The following is a description of a gene set: Genes predicted to be targets of miRBase v22 microRNA hsa-miR-548ag in miRDB v6.0 with MirTarget v4 prediction scores > 80 (high confidence targets). Human Gene Set: MIR548AG from publication Chen Y, Wang X (PMID 31504780) studied in species Homo sapiens, and this is the list of marker genes: CAMSAP2, SPDYE5, RNF38, FIP1L1, COG5, PSME3, LMBR1, RIOX1, TMEM200A, PSMA8, BCAT1, ZNF730, DENND4C, C4orf46, APPBP2, TRIM13, CEP97, PDE6C, DICER1, ZC2HC1C, C21orf91, PURB, PF4, DENND1A, STXBP1, NFYB, PAK2, PSD3, CYP2J2, RWDD4, CRISPLD1, PDLIM5, GDNF, IQCK, LPP, COX5A, POLR3G, SLC15A1, ZNF461, OBSL1, MORC3, CENPK, ITSN1, STAU2, ANKRD13A, ZEB2, LCOR, ZHX2, GNG12, P2RY12, BACH2, SLC25A12 (solute carrier family 25 member 12), KRTAP9-9, MRO, CRNKL1 (NCBI Gene Id 51340), RREB1, ULK2, U2AF1, RORB, DCAKD, UBE2W, SON, GASK1B, PCDH15, TPR, PCMTD1, CDC14A, C1orf115, TOMM5, CD164, TCFL5, HPCAL4, NEK2, MAP7, RGS9BP, SPDYE1, GPM6A, ZNF699, HELQ, PABPC5, INSIG1, SPDYE3, TNKS2, ZNF585B, MFN1, VAPA (VAMP associated protein A), ITPR3, PIK3C2B, RFXAP, HMCN1, ZNF777, SLC17A6, USP42, SP110, ZNF716, TMEM178B, ANKRD17, TMEM229A, BICD2, RBMXL3, PDE7A, DIXDC1, UBE2E3, GUCY1A2, BMP3, STAM, RDX, QKI, B3GNT5, SASS6, ZNF362, EFEMP1, WDR20, PSMD7, PDHA1, PPP3R1, LAMTOR5, ENSG00000275895 (NCBI Gene Id 102724594), KDM2B, TNIK, MPRIP, TRIP11, CDH19, PPP1R9A, FBXL4, TMPRSS11B, EPSTI1, MTUS1, NEMP1, MOB1B, ZNF43 (NCBI Gene Id 7594), PWWP2A, OIP5, NCKAP1, CMTM4, NEUROD1, BRMS1L, SVIL, DCP2, LSM8, TYMSOS, HSPA4L, AMER2, ELOVL5, TNRC6C, PWP1, SPDYE6, RGL1, CEP78, SPCS3, EHBP1, IFIT1B, ZNF770, TCERG1, SETD9, CERT1, ENPP4, NFE2L3, RHOA, NELL2, PRDM4, MBNL3, EPHB1, PCDH18, ZDHHC21, SEMA3C, SMAD2, GABARAPL1, PKD2